Given this list of marker genes ALAD, JMJD8, UNG, RAB34, CEP128, DUSP3, ACACA, CDK12, TIMM44, CPNE2, FOXG1, RUSF1, SAMHD1, CGAS, SH3PXD2B, UTP14A, NEO1, TRPC1, TERT, CYB561, ADAMTS2, PENK, TBL2, STXBP1, RAB38, SPTLC1 (serine palmitoyltransferase long chain base subunit 1), PRSS23 (serine protease 23), MAPKAPK3, MID1, ERG (ETS transcription factor ERG), GSS, KAT14, BLTP3A, GPATCH1, TFDP2, LPAR2, IGF2BP2, IQGAP3, RIMBP3C, ATAT1, COG7, SPATS2, TSR1, PTPRK, CYB5R1, PTPN13, LOXL1, RINT1, BCAT1, KCNH3, ARMC8, KHSRP, URGCP, PGD, AFG2A, PTPN21, BORA, MED18, DMRT3, E2F7, ASCC2, RPAP1, ABTB3, HOXA1, LRPAP1 (LDL receptor related protein associated protein 1), KLHL22, MAP9, CDIN1 (NCBI Gene Id 84529), CEP290, NPNT, C8orf76 (chromosome 8 open reading frame 76), KIF1B (NCBI Gene Id 57598), C7orf50, SCARA3, PRDM10, FEN1, TIAM1, PTER, CRCP, ADRB1, KATNAL1, SRR, GLI2, WDR90, PLCG2, ZNF518B, MBLAC2, CDS2, TBC1D24, PDGFRB, PIEZO1 (NCBI Gene Id 9780), GAB1 (NCBI Gene Id 2549), YJEFN3, FRS3, ERGIC1, SLC20A2, FANCM, VWCE, EPCAM, PLAGL1, FBXL20, PHACTR2, POLR3A, TMPRSS2, PIGO, BRCA2, OSBPL1A, TRMT61A, ABCA9, SEMA4A, SLC39A11, ZDHHC14, SUGP2, MMP2, RGS12, DPEP1, KAZALD1, LGI2, TXNRD3, NUP188, ZNF764, TRIP6, PLEKHG1, SBSN (NCBI Gene Id 374897), FAM234A, KBTBD13, SMYD4, NMT2, C4orf54, VWA8, PCOLCE, CCDC141, TSPOAP1, PML, CTSE, ARFGAP1, REEP1, EFEMP1, BBS1, NEK3, CCDC25, DUS3L, SCRT2, APLP2, HDAC11, ATG9A, HTRA3, DPAGT1, ABCC9, XIST, HEMGN, AFAP1L2, GPATCH2, RPS6KA6, THG1L, ATAD3A, LACC1, TM7SF2, CNKSR3, POLR3K, CA12, KLHDC9, POLR3E, TARS2, CDC25C, CD200, CARD10, AKAP5, CACHD1, MAPRE2, KRBA1, PLK2, SYK, EEF1AKMT1, NRCAM, DDX31, PTDSS2, SLC5A9, CIT, LYNX1, SLC39A14, TEDC1, CKAP4, VANGL2, POLD3, TAMALIN, AVEN, BTNL9, XRCC3, IMPDH2, RHOU (ras homolog family member U), IER3, CA7, PMF1, COPS7B, VAT1, TMEM107, ZDHHC24, MTAP, TSPAN9, here is a description of the gene set: studied in species Homo sapiens from publication Borjesson DL, Kobayashi SD, Whitney AR, Voyich JM, Argue CM, Deleo FR (PMID 15879137) Human Gene Set: GSE2405_HEAT_KILLED_LYSATE_VS_LIVE_A_PHAGOCYTOPHILUM_STIM_NEUTROPHIL_24H_DN Polymorphonuclear leukocytes (PMNs) were obtained from healthy individuals in accordance with protocols approved by the Institutional Review Board for Human Subjects at the University of Minnesota and the National Institute of Allergy and Infectious Diseases. PMNs (107) were combined on ice with live S. aureus (108) or with live or heat-killed A. phagocytophilum (bacteria isolated from 5x106 infected HL60 cells for a ratio of 1 infected HL60 cell: 2 PMNs, ~ 5-20 A. phagocytophilum: PMN) in wells of a 12-well tissue culture plate (pre-coated with 20% autologous normal human serum). Unstimulated control assays received either buffer (for S. aureus comparisons) or clarified HL60 lysate (for A. phagocytophilum comparisons). Plates were centrifuged at 350 x g for 8 min at 4oC to synchronize phagocytosis and incubated at 37 deg. C in a CO2 incubator for the indicated times. At the indicated times, tissue culture medium was aspirated from the plate and PMNs were lysed directly with RLT buffer (Qiagen, Valencia, CA). Purification of PMN RNA and subsequent preparation of labeled cRNA target was performed as described in Methods. Labeling of samples, hybridization of cRNA with HU133A oligonucleotide arrays (Affymetrix, Santa Clara, CA), and scanning were performed according to standard Affymetrix protocols ( http://www.affymetrix.com/pdf/expression_manual.pdf ). Experiments were performed in triplicate, using PMNs from three healthy individuals for each treatment. Genes down-regulated in polymorphonuclear leukocytes (24h): treated by heat killed HC60 cell (promyelocytic leukemia) lysate versus A. phagocytophilum infection.